The following is a description of a gene set: Any process that modulates the frequency, rate or extent of cellular response to heat. Human Gene Set: GOBP_REGULATION_OF_CELLULAR_RESPONSE_TO_HEAT species: Homo sapiens, and this is the list of marker genes: CHORDC1, SIRT1, HSF1, ATR, CREBBP, IER5, DNAJB6, DNAJB1, MAPT, MAPKAPK2, DNAJC7, EP300 (E1A binding protein p300), ATM, DNAJC2, GSK3B, MTOR